The following is a description of a gene set: Each fraction of mouse hematopoietic cells was purified by cell sorting from bone marrow of 8-week-old C57BL/6 mice, and its gene expression was analyzed. from publication Konuma T, Nakamura S, Miyagi S, Negishi M, Chiba T, Oguro H, Yuan J, Mochizuki-Kashio M, Ichikawa H, Miyoshi H, Vidal M, Iwama A (PMID 21540074) species: Homo sapiens Human Gene Set: GSE27786_NKTCELL_VS_MONO_MAC_UP Genes up-regulated in comparison of NKT cells versus monocyte macrophages., and this is the list of marker genes: HUWE1, SARS1, LAPTM5, ARK2C, CSTF2, SLC22A5, RPUSD4, MOSMO, EPS8L1, BABAM1, TMEM70, PTTG1, THEMIS, G3BP2, XAF1, BRD2, ACO2, XPO6, UBE3A, PLEKHF1, DDX54, NEMF, VIRMA, METTL13, SCAI, MSI2 (musashi RNA binding protein 2), CACYBP, HAUS3, NME7, SUCLG2 (NCBI Gene Id 8801), ADCY5, LAP3, LRIF1, CDK13, UQCC6, PRKAR1A, SYS1, STIP1, DHPS, ARHGDIA, XRCC5, IPO5, AQP2, CNBP, RPL27, RNF145, ACADVL, ECE1, VWCE, AKNA, SEMA3A, ARHGAP30, MEX3B, ARHGAP45, NONO, SF3A3, LYPD6B, THAP12, APPL2, GMPPA, GMDS, CAVIN4, NELFB, AP1AR, HSPE1 (NCBI Gene Id 82869), MED12, IFT70B, ZBTB7A (zinc finger and BTB domain containing 7A), SPRY2, TCHP, PRORP, OSBPL5, GSE1, YIPF5, MLH1, TFB2M, RAB10, BIN1, PRPSAP1, ORC5, MGA, ATG13, PFAS, SLC2A8, NDUFS3, ARFGAP2, ADI1, PATJ, RTN4RL1, SFMBT2, ATPAF1, COX17, STT3A, CHD8, IDH3B, COPS2, CMSS1, RBMS2, TRIM35, ADGRE5, ITPR2, RRM2B, HNRNPA3, NGLY1, IPO4, ZNF707, ARL2, INTS1, SACS, TIMM10, POLR1H, TSPAN32, TSHZ1, ANKRD44, SMC5, EIF3A, TAF4B, GPATCH1, CCT6A, CNDP2, SNX4, C17orf75, GCSH, TTC39B, TSPAN4, ZNRD2, GRAMD1B, IPO11, METTL5, ITGB3BP (NCBI Gene Id 23421), VPS39, RRP9, HARS1, CHORDC1, PRPF19, DMAC1, PPP2R2A, PDCD10, MYEF2, CDK8, MANF, TUBB3, PINK1, THADA, TIMM13, ALKBH7, PTGR3, RPL23 (ribosomal protein L23), NUP85, ITPK1, ZBTB45, ZMYND8 (NCBI Gene Id 55497), DESI2, SLC20A1, BEND3, MTHFD1L, HOOK1, ANAPC1, AGA, NUDCD1, APOOL, AIMP1, ZBTB8A, TAP1, LYST, YARS1, UBN2, STRAP, ARHGAP18, HARBI1 (NCBI Gene Id 283254), WRNIP1, MYO1E, JPT1, DDX39B, COX18, MRPS34, ZC3HAV1, TMEM69, PJA1, ARPC5L (actin related protein 2/3 complex subunit 5 like), SORBS1, SNHG6, FRA10AC1, EARS2, BCLAF1, GPR68, ORC4, INPP5B, YY1 (YY1 transcription factor), SIX6, RPS16, ZMAT2, KDM4D, SNRNP48, CDH8, DDX24, GPATCH8, PRKCSH, MOS, TVP23B